The following is a description of a gene set: Human Gene Set: HP_ABNORMAL_NASAL_SEPTUM_MORPHOLOGY An abnormality of the nasal septum. Abnormal nasal septum morphology studied in species Homo sapiens, and this is the list of marker genes: STING1, CREBBP, FLNB, TP63, NONO, NECTIN1, EXOSC5, RPS6KA3, SIX3, IRF6, ARSL, MYMX (myomixer, myoblast fusion factor), UBA1, TGIF1, MSX1, PAH, FGFR2 (NCBI Gene Id 2263), EP300, PIK3CA, ATP6V1B2, TFAP2A, NF1, PTCH1, NOG